The following is a description of a gene set: Mouse Gene Set: GOBP_OLFACTORY_BULB_INTERNEURON_DIFFERENTIATION The process in which a neuroblast acquires specialized features of an interneuron residing in the olfactory bulb. studied in species Mus musculus, and this is the list of marker genes: Uncx, Rac1, Gsx2, Mir9-1, Slit2, Mir200c, Sall3, Robo2, Mir9-3, Robo1, Mir429, Mir9-2, Dlx5, Mir200a, Mir200b, Erbb4, Mir376a, Fgfr1, Wnt5a, Dicer1, Arx, Sall1, Mir141, Atf5